Given this list of marker genes Mff, Stub1, Smad4, Rbm10, Il12b, Eif5a, Camk2d, Agt (angiotensinogen), Cxcr2, Ltk (NCBI Gene Id 17005), Igfbp3, Grp, Arrb1, Pten, Grk2, Atp2a2, Capn1, Hmgcr, Camk2a, Bnip3, Adcy10, Trp53, Pparg, Casp12, Atf4, Fndc1, E2f3, Cdkn2a, Mfn2, Capn2, Ifng, Stk4, Bag1, Pou4f2, Foxo1, Zfas1, Fbxo32, Tigar, Sod2, Ptpn1 (NCBI Gene Id 19246), Pdcd4, Mapk8, Map3k5, Trem1, Gata6, Il12a, here is a description of the gene set: studied in species Mus musculus Any process that increases the rate or frequency of muscle cell apoptotic process, a form of programmed cell death induced by external or internal signals that trigger the activity of proteolytic caspases whose actions dismantle a muscle cell and result in its death. Mouse Gene Set: GOBP_POSITIVE_REGULATION_OF_MUSCLE_CELL_APOPTOTIC_PROCESS